Given this list of marker genes RHOBTB3, TGFB2, RUNX1, ARL4C, SCAMP1, DIAPH1, SZRD1, HS2ST1, INSIG1, BCL11A (NCBI Gene Id 55085), FN1, PML, SEC23IP, TRPC1, PEG10, UBAP2L, here is a description of the gene set: Genes up-regulated in MDA-MB-231 cells (breast cancer) after knockdown of PRKCA and ETS1 by RNAi. Human Gene Set: VETTER_TARGETS_OF_PRKCA_AND_ETS1_UP from publication Vetter M, Blumenthal SG, Lindemann RK, Manns J, Wesselborg S, Thomssen C, Dittmer J (PMID 15531915) species: Homo sapiens PKCalpha and Ets1 are both associated with breast cancer progression. Our previous studies suggested that these proteins are likely to functionally interact with one another. Here, we show that attenuation of endogenous PKCalpha expression (siPalpha) by RNA interference leads to reduced Ets1 protein expression in a variety of cancer cells. Pulse-chase experiments and treatment with proteasome inhibitor MG-132 revealed that siPalpha interferes with both Ets1 protein synthesis and stability. The effect of siPalpha on Ets1 expression could be partially prevented by KN-93, suggesting that calcium/calmodulin-dependent kinase II (CaMKII), a modulator of Ets1 activity, may play a role in PKCalpha-dependent Ets1 regulation. In contrast, Ets1-regulating kinases ERK1/2 were not found to be involved in this process. To assess the importance of the PKCalpha/Ets1 interaction, we compared the biological responses of MDA-MB-231 cells to PKCalpha- and Ets1-specific siRNAs (siE1). While only siPalpha induced changes in cellular morphology and anchorage-independent growth, both siRNAs similarly affected cellular responses to the antitumor drug mithramycin A and to UV light. Microarray analyses further showed that the expression of a certain set of genes was equally affected by siPalpha and siE1. The data suggest that Ets1 serves as an effector for PKCalpha to fulfil certain functions in cancer cells.